Given this list of marker genes Snf8, Chmp3, Chmp4c, Rab27a, Chmp2b, Vps4a, Chmp4b, Chmp6, Vps4b, Chmp1b, Chmp7, Chmp1b2, Chmp5, Chmp2a, Chmp1a, Rab11a, here is a description of the gene set: Mouse Gene Set: GOBP_MULTIVESICULAR_BODY_ORGANIZATION A process that is carried out at the cellular level which results in the assembly, arrangement of constituent parts, or disassembly of a multivesicular body. A multivesicular body is a type of late endosome in which regions of the limiting endosomal membrane invaginate to form internal vesicles; membrane proteins that enter the internal vesicles are sequestered from the cytoplasm. species: Mus musculus